Given this list of marker genes Bcl2a1d, Taf10, Fdps, Syncrip, Cdk2ap1, Nip7, Bysl, Ncf4, Mast3, Pa2g4, Aprt, R3hdm4, Ldha, Ranbp1, Ppp1r14b, Mrpl27, Etfa, Gtpbp4, Dnajb11, Shmt2, Thumpd1, Gnl3, Atic, Mettl1, Zfp593, Rsl1d1, Uqcc2, Gstp1, Aff1, Atad3a, Pdia4, Map4k1, Pole4, Rrp9, Nifk, Pfn1, Nme1, Eif5a, Gpatch4, Mphosph10, Pdia3, Napsa, C1qbp, here is a description of the gene set: Genes positively differentially expressed in cell type: B cell upon treatment with cytokine: IL-5 in mouse lymph nodes in vivo. from publication Cui A, Huang T, Li S, Ma A, Pérez JL, Sander C, Keskin DB, Wu CJ, Fraenkel E, Hacohen N (PMID 38057668) species: Mus musculus Mouse Gene Set: CUI_B_CELL_IL5_RESPONSE_UP Cytokines mediate cell-cell communication in the immune system and represent important therapeutic targets. A myriad of studies have highlighted their central role in immune function, yet we lack a global view of the cellular responses of each immune cell type to each cytokine. To address this gap, the authors created the Immune Dictionary, a compendium of single-cell transcriptomic profiles of more than 17 immune cell types in response to each of 86 cytokines (>1,400 cytokine-cell type combinations) in mouse lymph nodes in vivo. A cytokine-centric view of the dictionary revealed that most cytokines induce highly cell-type-specific responses. For example, the inflammatory cytokine interleukin-1β induces distinct gene programmes in almost every cell type. A cell-type-centric view of the dictionary identified more than 66 cytokine-driven cellular polarization states across immune cell types, including previously uncharacterized states such as an interleukin-18-induced polyfunctional natural killer cell state.